Given this list of marker genes DPY19L4, EXOC6B, INTS8, ERP27, ATP6V0C (ATPase H+ transporting V0 subunit c), KLF2, NUP43, RPS6KA4 (NCBI Gene Id 8986), LRRC40, VPS28, GPAA1, NSF, C2CD3, SAC3D1, ANAPC16, NAPEPLD, MIR663AHG, FYCO1, SNRK, SULT1A1, TMCO6, SLC7A8, MPI, ZNF565, HFE, ATRX, GOLGA8H, IMPACT, TUBGCP4, BBX, PAPSS1, MMD, H4C2, BRD3OS, SEPTIN2, STK38 (NCBI Gene Id 11329), GPI, CENPK, JKAMP, NDRG3, SKP2, SLC27A3, CACNA2D4, STT3B, XRCC5, PITHD1, CNRIP1, ENSG00000290941 (novel transcript), KHK, XPO1, ZNF875, NISCH, ADARB2, ARMCX1, OXR1, LDHA, ELAC2 (elaC ribonuclease Z 2), BRD8, STK32C, PRIM1, ADCY9, PPM1K, ID1, SMIM19, CBR4, PEBP1, SYF2, SLC41A3, TFPI2, TMEM127, IGBP1, IPO8, GPALPP1, NQO2, MEGF8, PTPRA, OR1J4, ZDHHC3, CHST12, AASDHPPT, ZNF823, ZDHHC7, SUMO3, ZNF251, ACAA1, NME4, TIMMDC1, UBA7, NSMCE1, ZNF117 (zinc finger protein 117), ERMP1 (endoplasmic reticulum metallopeptidase 1), SNORA71A, CDKAL1, FCGR2C, PDGFC, BMPR2, ALDH3B1, PPP2R5A, FGFBP2, FAM120C, TEX13A, RGS19, C14orf119, TGOLN2, TARS2, TXNDC16, INTS3, ZNF248, CSTPP1, EPHB3, NPRL2, CUEDC2, EIF4A3, ATPAF1, JMJD1C, NFU1, PRPS2, FAM149B1, PMPCB, IFT27, STAU2, COMT, GLIPR1, POLR2G, TMED10, PLCB2, NATD1, PIP, GCHFR, AKAP9, ZFTRAF1, TPT1, MAD1L1, ZC3H6, SGSM2, REPS1, MGST2, RPAP3, HCG11, PKP4, FMO5, PKIB, H2AJ, USP51, CPT1A (NCBI Gene Id 1374), SRPK1, CRBN, SF3A1, ATXN10, C5orf34, SPTAN1, LZTFL1, OGT, RPS6KA2, UBTF, ITGB5, EPHB2, ELAVL1, UNC5CL, STN1, THAP10, HMOX1 (heme oxygenase 1), SSBP3, LINC00910 (NCBI Gene Id 100130581), SFR1, MAVS, LRRC39, XYLT1, RFXAP (NCBI Gene Id 5994), ATP13A1, SIPA1L2, MTFMT, PIP4K2B, ASGR1, DPYD, TMX4, RTN3, FZD10, PAPOLA, TRAPPC1, TRMT11, ZNF788P, H2BC8, SORT1, CENPU, PARP2, KIAA2013, CDK2AP1, SARAF, METTL26, FOXO4, BDH2, TBC1D5, LNPK, ZNF124, here is a description of the gene set: species: Homo sapiens Genes up-regulated in comparison of macrophages cultured with M-CSF versus macrophages cultured with M-CSF, IFNG and Pam3Cyc. from publication Hu X, Chung AY, Wu I, Foldi J, Chen J, Ji JD, Tateya T, Kang YJ, Han J, Gessler M, Kageyama R, Ivashkiv LB (PMID 18976936) Human Gene Set: GSE11864_CSF1_VS_CSF1_IFNG_PAM3CYS_IN_MAC_UP Gene expression analysis of freshly isolated CD14+ human monocytes and monocytes cultured in the presence or absence of interferon (IFN) -gamma for 24 h and then stimulated with Pam3Cys, a Toll-like receptor (TLR) 2 ligand, for 6 h. Results provide insight into mechanisms by which IFN-gamma reprograms early macrophage differentiation and subsequent response to TLR ligands.